The following is a description of a gene set: species: Homo sapiens Human Gene Set: HP_LYMPH_NODE_HYPOPLASIA Lymph node hypoplasia Underdevelopment of the lymph nodes., and this is the list of marker genes: BTK, EPHB4, DCLRE1C, IL2RG, PNP